The following is a description of a gene set: Human Gene Set: GSE16266_LPS_VS_HEATSHOCK_AND_LPS_STIM_MEF_UP species: Homo sapiens from publication Takii R, Inouye S, Fujimoto M, Nakamura T, Shinkawa T, Prakasam R, Tan K, Hayashida N, Ichikawa H, Hai T, Nakai A (PMID 20018623) To clarify inflammatory genes whose expression is suppressed at high temperatures, we performed comprehensive analysis of gene expression by using a DNA microarray. Two independent primary cultures of mouse embryo fibroblasts (MEF1 and MEF2) were treated with LPS for 4 hours, or treated with LPS for 4 hours after the pretreatment with heat shock at 42˚C for 1 hour, and we identified genes that undergo more than a 3-fold increase with LPS treatment. Remarkably, genes (86%) underwent less than a 2-fold increase after combined treatments with heat shock and LPS in MEF1 and MEF2 cells. Genes up-regulated in mouse embryonic fibroblasts (MEF): LPS versus LPS and heat shock., and this is the list of marker genes: CCDC137, RUNDC3A, PDK4, SYT10, SPIB (NCBI Gene Id 6689), STAU2, FUOM, SHISA2, TNFRSF13C, ECHDC3, CD209, LYZL1, POU2AF1, GJA10, CXCR5, LMO2, ZNF318, PRDM9, BLNK, TMEM51, SRSF5, IRF5, CD8A, TNFSF8, PPT1, NKAIN1, SOX12, TBXT, FGD2, TEC, CLU, CD19, PKP2, LIMD1, CAPN3, TNFRSF13B, CLPS, CIP2A, SEPSECS, ABCC3, DDC, NAPSA, LY86 (lymphocyte antigen 86), SWAP70, NFIB, EVI2B, KLK7, CLEC16A, ZNF296, CERT1, GGA2, CD207, CD8B, TTC8, TXNDC17, IL36A, TMEM106C, AGAP1, CXCR6, MYO1C, ITGAE, DNAJC27, NRDC, SYNGR2, NKG7, IGKC, CREB3L1, SULT1A1, APC2, PLCG2, HLA-DRB1, PLD4, PDCD7 (NCBI Gene Id 10081), TCF4, XPO5, CXCR3, DCN, CALHM2, SIX2, HLA-DOB, SLURP1, IRF8, MEF2C, NPRL3, RENBP, P2RX3, RAB25, ALDH1L1, JCHAIN, GPX5, IFI30, CCR6, CTSH, BMP8A, HEMK1, C19orf44, PLAC8, FCER2, TAC1, PLBD1, BTK, CENPK, CLK1, S100A4, RIPK2, BIRC3, TFAP2D, DHRS3, TYMS, TIFA, CR2, CASK, PLA2G2F, C19orf73, GUCY1B1, DSC3, RASSF2, TMEFF2, ADCY2, DYNLT3, CDON, BCL11A, SNRNP27, FBXO16 (NCBI Gene Id 157574), CRTAP, GIMAP1, MYADM, IRX3, ODF1, CD22, ADAMTS1, UGT2B10, HSD17B1, PRKACB, PLEK, CDK1, LRP4, B3GAT1, SLC38A4, TCEA2, LPAR1, CD40, DCUN1D1, BLK, LY6D, HNRNPH2, SORL1, LYL1, CSN3, GCH1, IFT70B (NCBI Gene Id 150737), MS4A1, AIG1, RNF41, C11orf91, HMBOX1, NUFIP1, SYPL1, VWA8, CD79B, ANGPTL7, ATM, CD79A, ANKRD46, HLA-DMA, KRT7, CD72, ZNF227, CCDC88C, HLA-DQA1 (NCBI Gene Id 7946), ILF2 (NCBI Gene Id 3608), CD83, CPA5, PTGS1, CHFR, CD74, BCL2L14, PLCB3, KLF12, LTBP2, MKI67, CSF2RB, RASL10A, EPB41L2, PAX3, FCRL1, GCC1 (GRIP and coiled-coil domain containing 1), MAG, EHD4, SLC10A6, IFT88, CST7, SYK, PTH, MYLK2, CIITA, HLA-DOA, SCD, TGFBI